Given this list of marker genes TTLL7, TTLL1, CFAP20, CEP41 (centrosomal protein 41), TTLL4, TTLL6 (tubulin tyrosine ligase like 6), here is a description of the gene set: Human Gene Set: GOBP_PROTEIN_POLYGLUTAMYLATION The addition of one or more alpha-linked glutamyl units to the gamma carboxyl group of peptidyl-glutamic acid. species: Homo sapiens